Given this list of marker genes GRB2, PIK3R1, HRAS, FRS2, NRAS, SOS1, KRAS (NCBI Gene Id 3845), PIK3CA, PLCG1, FGFR4, GAB1, here is a description of the gene set: Signaling by FGFR4 in disease Human Gene Set: REACTOME_SIGNALING_BY_FGFR4_IN_DISEASE species: Homo sapiens